Given this list of marker genes Akr1c13, Cyp7a1, Abcb11, Osbp, Ncoa1, Akr1c14, Nr1h4, Akr1c20, Amacr, Cyp8b1, Akr1c18, Osbpl6, Slc27a5, Akr1c21, Osbpl2, Akr1c6, Cyp39a1, Akr1d1, Acot8, Acox2, Osbpl7, Slc27a2, Baat, Hsd17b4, Cyp46a1, Ch25h, Osbpl1a, here is a description of the gene set: species: Mus musculus Reactome Pathway: Synthesis of bile acids and bile salts This event has been computationally inferred from an event that has been demonstrated in another species.<p>The inference is based on the homology mapping from PANTHER. Briefly, reactions for which all involved PhysicalEntities (in input, output and catalyst) have a mapped orthologue/paralogue (for complexes at least 75% of components must have a mapping) are inferred to the other species. electronically inferred by orthology from the curated human pathway part of: Bile acid and bile salt metabolism